The following is a description of a gene set: Human Gene Set: GOBP_POSITIVE_REGULATION_OF_PROTEIN_LOCALIZATION_TO_SYNAPSE studied in species Homo sapiens Any process that activates or increases the frequency, rate or extent of protein localization to synapse., and this is the list of marker genes: CLSTN3, MAPT, NLGN2, WNT5A, WNT7A, DVL1